Given this list of marker genes Oas1b, Il6st, Oas1c, Oasl1, Stat1, Il27ra, Oas1e, Oas3, Oas1d, Oasl2, Oas2, Oas1g, Oas1a, Oas1f, Oas1h, here is a description of the gene set: species: Mus musculus The series of molecular signals initiated by interleukin-27 binding to a receptor on the surface of a target cell, and ending with the regulation of a downstream cellular process, e.g. transcription. Mouse Gene Set: GOBP_INTERLEUKIN_27_MEDIATED_SIGNALING_PATHWAY